Given this list of marker genes ITGA2, C3, GATA2, STAP1 (NCBI Gene Id 26228), ALOX15, APPL2, ANO6, RAB31, PLCG2, F2RL1, CD300A, CD36, NCKAP1L, TREM2, ABCA7, here is a description of the gene set: Human Gene Set: GOBP_REGULATION_OF_MEMBRANE_INVAGINATION species: Homo sapiens Any process that modulates the frequency, rate or extent of membrane invagination.